Given this list of marker genes BBS7, ASIP (NCBI Gene Id 434, agouti signaling protein), BBS2, DCTN2, RAB1A, MREG, BBS5, GPR143, ARL6, MYO7A, RAB27A, CDH3, VPS33B, MAP2K1, BLOC1S3, DCTN1, VPS33A, RAB11A, BLOC1S6, BLOC1S5, MYO5A, MKKS, MLPH, RAB17, RAB11B, SHROOM2, here is a description of the gene set: Any process in which a pigment granule is transported to, and/or maintained in, a specific location within the cell. studied in species Homo sapiens Human Gene Set: GOBP_PIGMENT_GRANULE_LOCALIZATION